The following is a description of a gene set: Mouse Gene Set: GOMF_STRUCTURAL_CONSTITUENT_OF_CYTOSKELETON species: Mus musculus The action of a molecule that contributes to the structural integrity of a cytoskeletal structure., and this is the list of marker genes: Ina, Nefh, Actn2, Tubb2b, Prph, Loricrin, Add3, Arpc4, Nefm, Crocc (NCBI Gene Id 230872), Actr2, Tpm1 (tropomyosin 1, alpha), Myl9, Plec, Mybpc1, Krt71, Tuba3a, Tuba1b (tubulin, alpha 1B), Lmnb1, Tnnt2, Sptbn1, Add2, Synm, Tln2, Odf2, Tuba4a, Arpc2, Tubb4b, Tubal3, Tpm2, Camk2b, Sprr1b (NCBI Gene Id 20754), Tubb2a, Tubg1, Dbnl, Actbl2, Arpc5, Actr3, Mybpc3, Gfap, Ank2, Tuba1a, Myom2 (myomesin 2), Ttn, Epb41l3, Krt16, Lmna, Mybpc2, Arpc1b, Sprr2a1, Sptb, Arpc3, Des (desmin, NCBI Gene Id 13346), Tubb4a, Tln1, Ank3, Acte1, Tubb3, Epb41, Myom1, Vim, Tubb1, Tube1, Tubb6, Actg1, Tubb5, Add1, Actn4, Tuba8, Nefl, Tubd1, Pls3, Lmnb2, Actb, Tuba1c